Given this list of marker genes POT1, SHQ1, TERF1, TINF2, CCNA1, CCNA2, TERF2, RTEL1, PIF1, WRAP53, PPP6C, NHP2, ACD, RUVBL2, DKC1, TERT, RUVBL1, TERF2IP, GAR1, CDK2, ANKRD28, NOP10, PPP6R3, here is a description of the gene set: Telomere Extension By Telomerase Human Gene Set: REACTOME_TELOMERE_EXTENSION_BY_TELOMERASE studied in species Homo sapiens